The following is a description of a gene set: Any process that modulates the frequency, rate or extent of somitogenesis. studied in species Mus musculus Mouse Gene Set: GOBP_REGULATION_OF_SOMITOGENESIS, and this is the list of marker genes: Pax3, Cdx2, Cdx1, Notch1, Dll1, Dmrt2, Lfng